Given this list of marker genes MPP1, MCUB, SMNDC1, ZNF37A, SLC4A4, INTS6, SCN8A, MCOLN3, ABI2, CTTN, CFHR4, KREMEN1, TBC1D1, SLC9A4, CMKLR2, RYR2, TOM1L1, TPD52, TNPO1, IMMT, TWSG1, SBNO1, FMN2, FAM120A2P, CEP128, BTC, GPR37, CPSF6, SRPK1, SIRPA, GGNBP2, CTNNB1, HMGA2, CFHR3, FAM120A, C14orf28, ASB7, GIPC2, DENND5A, LRRC55, KANSL1L, CAMK2N1, SNRPF, ZFP36L1, TCF7L2, GAS1, COPS8, ATP2C1, HNRNPD, ZC3H13, PAIP1, CHIC1, PXDNL, NCOA2, TIMM9, MAFB, NOL4L, CPSF2, VCAM1, ZNF470, BTN3A1, POU4F2, FOXN2, DIPK2A, ZNF281 (zinc finger protein 281), CAMTA1, PPM1L, SLC45A4, ZNF417, here is a description of the gene set: Genes predicted to be targets of miRBase v22 microRNA hsa-miR-495-5p in miRDB v6.0 with MirTarget v4 prediction scores > 80 (high confidence targets). studied in species Homo sapiens Human Gene Set: MIR495_5P from publication Chen Y, Wang X (PMID 31504780)